Given this list of marker genes SSU72 (NCBI Gene Id 79588), PDE4C, OPCML (opioid binding protein/cell adhesion molecule like), PFKFB2, BAZ2B, HOOK3, FBXO11, GCLM, HNMT, CCDC112, BSCL2, TRDMT1, ZNF704, C11orf58 (NCBI Gene Id 10944), UNC5C, TAP2, UQCC1, GFPT1, CA12 (NCBI Gene Id 771), MYB, ACKR2, CAMK4, HOPX, RINT1, ZFYVE26, PGRMC2, PRKDC, ANKRD17, RAB3C, SMARCD1, IFT56, ZNF154, C11orf87, REEP4, EML4, COX11, GATA3, ARG2 (arginase 2), LRATD2, PRDM5, GABRB2, SETD9, QKI (QKI, KH domain containing RNA binding), TGFBRAP1, PLXNA2, PAX7, TKTL1, CPD, THSD7A, KBTBD7, CDIN1, FAM13B, CDCP1, PLCH1, GSTM4, GRHL2, ADGRF2P, GARRE1, SDK1, PARP14, RAPGEF6, DDAH1, POU2AF1, GPC6, C9orf152, LENG8, NBL1, PSME3, PRRC1, ZNF317, DEPDC5, TMEM33, ERC2, GUCY1A2, C5AR2, OPRM1, DMD, USP7, DUSP10, EDEM3, CNBD2, ABCD3, SLC22A23, SUGT1, HDAC9, BAG1, TPM4, PRRC2B, EHD2, TMEM138, SLC66A3, AP3M1, FCGR1BP, HS6ST2, ATP2B1, PEG10, TM9SF4, NALF1, HCN4, TMEM127, VPS53, PDP2, EPHA7, ELAVL4, ZNF592, MARCHF9, SMIM43, SPTSSB, MKLN1, GID4 (GID complex subunit 4 homolog), ARK2C (NCBI Gene Id 494470), PBLD, FBXO47, PDE4B, AMMECR1, VPS26C, BAALC, PALM2AKAP2, CAMK2D, ZNF585B, SNX27, ZNF142, MAN1A2, RORC, PAQR9, CA10, CEP350, TNFRSF11A, POM121C, HNRNPA2B1, SOX5, HOXA5, ACO1, AGO1, TRIM41, ZNF264, SLC24A2, ELP4, HTR2C, RGS7, RFX3, PRKD3, ST3GAL2, RALGAPB, STAT1, CADM1, PPTC7, XPO7, UBQLN2, GNB1, SNX18, MEIG1, HMGXB4, CAPZA1, LRRTM4, PHLDA3, EIF4EBP2, MTCL3, CDC14A, APLF, KIAA1549, PTAR1, SKA2 (NCBI Gene Id 348235), GRM5, NR2F2, CPT1A, FBN1, SGIP1 (SH3GL interacting endocytic adaptor 1), LPP, HMG20A (high mobility group 20A), DLGAP5, LRRC41 (leucine rich repeat containing 41), GLRX, CAND1, BCL7A, ITCH, NUDT9, SRPK1, FOXP1, CAMTA1, C2CD3, ARHGAP11A, UTRN, ANKRD44, DOK6, PTP4A1, EDEM1, PARP11, SYN3, FBXO42, BEST2, CPEB3 (NCBI Gene Id 22849), ENTPD7, TRIQK, KDM5A, ATXN7L3, INO80, CD209, RTKN2, CSRNP3, CRY2, FRMD5, SLC26A8, NDUFA5, RIMKLB, FAM120A, SRP54, CLPB, RFX4, NFIB, LSAMP, TAS2R5, ERP27, SLC2A13, PTER, GYPA, RAPH1, GRIA3, CLPX, TMEM59L (NCBI Gene Id 93030), FAAH2, AAK1 (AP2 associated kinase 1), HS6ST3, WASF2, IL2RG, JPH2, MAPK1, CYRIA, GFI1, GCM1, KMT2A, KCNQ3, PRKAR2A, MYH10 (myosin heavy chain 10), VGLL3, SAMD12, PPP1R3C, ITGAE, OLAH, HEBP1, PPM1N (NCBI Gene Id 147699), SH2B3, CXCL9, DKK2, LPAR6, GSTM5, CNTNAP2, OSBP, CARMIL1, CORO2B, PNMA2, CNTN1, C8orf48, PLPP5, ZMAT1, MED13L, GSG1, BSN, CD4, SMAD1, NDUFA10, SH3TC2, KRTAP7-1, CLTA, STAU2, SKIC3, REEP1, TPM3, ZFTA, NUFIP2, SCIN, E2F7, A1CF, EGFR (epidermal growth factor receptor), LIN54, PARVA, MAGOHB, KIAA1671, IP6K3, SUN1, KIAA0408, DCX, AKT3, TPRX1, VSIG1, SINHCAF, ZBTB20, TMEM121B, SLC39A9, BMPR2, PPP4C, PTPRE, THEM4, POM121, IGF1, ZNF770, DNM3, ZNF423, SNTB2, PPP1R1A, FGF12, ITGA6, NPTX1, RNF8, WDR26, KNCN, GHR, TBX3, SLITRK5, SEMA6A, MPRIP, PACS1, PRPF40A, XPR1, ZIC4, PROX1, NCBP2, SLC10A7, HCCS, TTPAL, KPNA4, NACC2, SAMD4A, GLTP, TRIM71, EXOC6B, PRSS16, NRG2, BSG, here is a description of the gene set: from publication Chen Y, Wang X (PMID 31504780) Human Gene Set: MIR1252_5P studied in species Homo sapiens Genes predicted to be targets of miRBase v22 microRNA hsa-miR-1252-5p in miRDB v6.0 with MirTarget v4 prediction scores > 80 (high confidence targets).